Given this list of marker genes Gstp1, Foxm1, Qars1, Ppia, Map3k20, Dusp10, Foxo1, Pbk (PDZ binding kinase), here is a description of the gene set: Any process that stops, prevents, or reduces the frequency, rate or extent of signaling via the stress-activated protein kinase signaling cascade. Mouse Gene Set: GOBP_NEGATIVE_REGULATION_OF_STRESS_ACTIVATED_PROTEIN_KINASE_SIGNALING_CASCADE species: Mus musculus